The following is a description of a gene set: Mouse Gene Set: GOBP_ESTABLISHMENT_OF_ENDOTHELIAL_BARRIER studied in species Mus musculus The establishment of a barrier between endothelial cell layers, such as those in the brain, lung or intestine, to exert specific and selective control over the passage of water and solutes, thus allowing formation and maintenance of compartments that differ in fluid and solute composition., and this is the list of marker genes: Pecam1, Marveld2, Cldn1, Fasn, Hpse, Vcl (NCBI Gene Id 268722), Afdn, F2rl1, Robo4 (NCBI Gene Id 74144), Pde4d, Myd88, Tnfrsf1a, Plcb1, Rapgef2, Add1, Cdh5, Cldn3, Msn, Ezr, Mir874, Zdhhc21, Ppp1r16b, Tjp1, Rap1b, Vegfa, Rock1, Pde2a, Sox18, S1pr3, S1pr2, Rdx, Foxp3, Cldn5, Proc, Tjp3, Ikbkb, Tnf, F11r, Rap1a, Akap11, Ptprs, Ednra, Icam1, Myadm, Ednrb, Dicer1, Abcb1b, Rock2, Rapgef1, Il1b, Tjp2, Edn1, Rapgef3, Rap2c